The following is a description of a gene set: Reactome Pathway: Somitogenesis part of: Formation of paraxial mesoderm Somites are bounded segments of mesenchyme that are periodically cleaved, or segmented, from the developing anterior paraxial mesoderm. Somite formation is conceptualized using a clock and wavefront model. The clock is present in cells of the presomitic mesoderm and cycles between a permissive state in which segmentation can occur and a refractory state in which it cannot. The wavefront moves along the presomitic mesoderm and causes segmentation where and when it encounters cells in the permissive state, thus the size of the somites is determined by the periodicity of the clock and the migration speed of the wavefront.<br>The segmentation process is driven by WNY signaling, FGF signaling, and especially the Notch signaling, Hubaud and Pourquie 2014). The intersection of posterior-anterior gradients of WNT and FGF signaling and an anterior-posterior gradient of retinoic acid signaling regulates the position of somite boundaries as perturbation of any of the gradients affects somite boundaries. Thus WNT, FGF, and retinoic acid appear to form the wavefront, also called the determination front. Segmentation periodicity is controlled by HES7-mediated negative feedback loops in the Notch pathway, which constitute a molecular oscillator or segmentation clock. Activation of LFNG expression by Notch and inhibition of Notch signaling by LFNG, possibly via regulation of the DLL3 ligand, constitute another negative feedback loop that acts as a molecular oscillator. Clock oscillations are initiated in nascent presomitic mesoderm in the primitive streak of the gastrulating embryo and posterior-to-anterior waves sweep to anterior paraxial mesoderm to regulate MESP2/RIPPLY2 expression to initiate segmentation. MESP2 activates expression of EPHA4, an Eph receptor that participates in segment boundary formation. MESP2 also activates expression of RIPPLY2, an inhibitor of TBX6. TBX6 is an activator of MESP2, therefore MESP2 indirectly inhibits its own expression via RIPPLY2.<br>Mutations in components of the segmentation clock, for example DLL3, MESP2, LFNG, and HES7, cause congenital vertebral defects in humans. species: Homo sapiens, and this is the list of marker genes: HES7, PSMA2, PSMD6, PSMB4, PSMC3, PSMA3, PSMB7, SEM1, PSMB1 (proteasome 20S subunit beta 1), PSMD7, PSMA7, EPHA4, PSMA6, PSMD3, PSMD8, MSGN1, PSMD13, PSMD1, ADRM1, LEF1, MESP2, PSMB5, PSMB3 (NCBI Gene Id 5691), PSMB2, PSMC6, RIPPLY2, CTNNB1, PSMB6, PSMC1, LFNG, RBPJ, DLL1, PSMC2, TBX6, PSMC5, PSMD14, PSMD11, NOTCH1, PSMA1, PSMD12, PSMD2, PSMA4, PSMA5, DLL3, PSMC4